The following is a description of a gene set: studied in species Homo sapiens Genes significantly (FDR < 10%) down-regulated in IMR-90 cells (fibroblast) in response to bystander irradiation. Background: The existence of a radiation bystander effect, in which non-irradiated cells respond to signals from irradiated cells, is now well established. It raises concerns for the interpretation of risks arising from exposure to low doses of ionizing radiation. However, the regulatory mechanisms involved in the bystander response have not been well elucidated. To provide insight into the signaling pathways responding in bystanders, we have measured global gene expression four hours after bystander and direct alpha particle exposure of primary human lung fibroblasts. Results: Although common p53-regulated radiation response genes like CDKN1A were expressed at elevated levels in the directly exposed cultures, they showed little or no change in the bystanders. In contrast, genes regulated by NF_B, such as PTGS2 (cyclooxygenase-2), IL8 and BCL2A1, responded nearly identically in bystander and irradiated cells. This trend was substantiated by gene ontology and pathway analyses of the microarray data, which suggest that bystander cells mount a full NF_B response, but a muted or partial p53 response. In time-course analyses, quantitative real-time PCR measurements of CDKN1A showed the expected 4-hour peak of expression in irradiated but not bystander cells. In contrast, PTGS2, IL8 and BCL2A1 responded with two waves of expression in both bystander and directly irradiated cells, one peaking at half an hour and the other between four and six hours after irradiation. Conclusion: Two major transcriptional hubs that regulate the direct response to ionizing radiation are also implicated in regulation of the bystander response, but to dramatically different degrees. While activation of the p53 response pathway is minimal in bystander cells, the NF_B response is virtually identical in irradiated and bystander cells. This alteration in the balance of signaling is likely to lead to different outcomes in irradiated cells and their bystanders, perhaps leading to greater survival of bystanders and increased risk from any long-term damage they have sustained. Human Gene Set: GHANDHI_BYSTANDER_IRRADIATION_DN from publication Ghandhi SA, Yaghoubian B, Amundson SA (PMID 19108712), and this is the list of marker genes: CNTNAP3, EPHB3, SMAD6, RGMA, MYH11, USP41P, S100P, EPHA4, CNKSR3, SLC5A3, WWOX, MAPT